The following is a description of a gene set: studied in species Mus musculus The process in which a relatively unspecialized cell acquires specialized features of a ventricular cardiac muscle cell. Cardiac muscle cells are striated muscle cells that are responsible for heart contraction. The ventricle is the part of the heart that pumps blood out of the organ. Mouse Gene Set: GOBP_VENTRICULAR_CARDIAC_MUSCLE_CELL_DIFFERENTIATION, and this is the list of marker genes: Mef2c, Fhl2, Rxrb, Cdk1, Myocd, Bmp10, Hey2, Nrg1, Myh10, Prox1, Pitx2, Nkx2-6, Rxra, Rara, Mef2a, Rarb, Lmna, Atg5, Nkx2-5